The following is a description of a gene set: studied in species Mus musculus Interleukin-1 signaling Mouse Gene Set: REACTOME_INTERLEUKIN_1_SIGNALING, and this is the list of marker genes: Il1b, Traf6, Psmd13, Il1r2, Irak4, Casp8 (NCBI Gene Id 12370), Psmd2, Irak2, Tollip (NCBI Gene Id 80650), Peli1, Nfkb2, Psma2, Psma1, Traf2, Ube2n, Nkiras2, Psmd7, Ube2v1, Il1rap, Psmd11, Peli2, Alpk1 (alpha-kinase 1), Fbxw11, Chuk, Irak1, Psmd12, Nlrc5, Irak3 (interleukin-1 receptor-associated kinase 3), Nfkbia, Sqstm1, Nlrx1, Psmb5, N4bp1, Tab2, Tab3, Psma7, Psmb1, Map3k7, Rps27a, Tifa, Ubc, Peli3 (pellino 3), S100b, Ager, Psmd8, Ikbkg, Psmd3, Ikbkb, Map2k6, Il1r1, Psmc3, Usp18, Psmc6, Hmgb1, Psmb7, Psmc1, Nkiras1, Skp1, Psma5, Psmb6, Psmb4, Lrrc14, App (NCBI Gene Id 319425), Ubb (ubiquitin B), Tnip2, Psmc4, Psma4, Uba52rt, Psmd1, Tab1, Usp14, Myd88, Map3k3, Psmd14, Psmb2, Rela, Psma6, Uba52, Map3k8, Il1rn, Nfkb1, Adrm1, Il1a, Nfkbib, Psmc2, Psmd6, Cul1, Rbx1, Psmc5, Psmb3, Psma3